The following is a description of a gene set: species: Mus musculus Mouse Gene Set: GOMF_CALCIUM_INDEPENDENT_PHOSPHOLIPASE_A2_ACTIVITY Catalysis of the reaction: phosphatidylcholine + H2O = 1-acylglycerophosphocholine + a carboxylate. This reaction does not require Ca2+., and this is the list of marker genes: Pla2g15, Pla2g5, Plb1, Prdx6, Pla2g4a, Pla2g6, Pla2g4c, Pla2g7, Prdx6b, Pnpla8